The following is a description of a gene set: The process whose specific outcome is the progression of a myeloid cell over time, from its formation to the mature structure. species: Mus musculus Mouse Gene Set: GOBP_MYELOID_CELL_DEVELOPMENT, and this is the list of marker genes: Hba-a1, Alas1, Ankle1, Cebpb, Gp9, Nckap1l, Zbtb7a, Ninj1 (ninjurin 1), Hbb-bs, Diaph3 (diaphanous related formin 3), Klf2, Zfpm1, Vps33b, Rabgap1l, G6pdx, Wasf2, Abcb10, Itgam, Klf1, Maea, Foxp1, Bcl6, Epo (erythropoietin), Anxa2, Rhd, Tjp2, Atp6ap1, Mpig6b, Arid4a, Tesc, Src, Trim58, G6pd2, Gp5, Evi2b, L3mbtl3, Ank1, Slc11a2, Pabpc4, Alas2, Slc9b2, Gp1ba, Fbxw7, Dmtn, Tnfsf11, Heatr3, Csf1r, Adgrf5, Fli1, Meis1, Cited2, Sox6, Rac2, Sh2b3, Flvcr1, Slc25a40, Gpr68, Hba-x, Rps6, Ptpn6, Thpo, Pla2g10, Notch2, Ltf, Ptpn11, Pip4k2a, App, Gm15915, Tal1, Lrrk1, Gata1, Brd1, Hba-a2 (NCBI Gene Id 15123), Myb, Gp1bb, Tmod3, Bap1, Rhag, Tyrobp, Ep300, Zfp385a, Flna, Adgrf4, Kit, Tlr2 (toll-like receptor 2), Abi1, Nrros, Fam20c, Ptbp3, Tspan2, Nbeal2, Ercc2, Bloodlinc, Rac1, Pafah1b1, Cldn18, Nemp1, Bpgm, Fam210b, Siglec15, Epb42, Med1, Jmjd6, Lyar, Hdac6, Fbn1, Srf, Slc4a1